The following is a description of a gene set: A type of adult onset with onset of symptoms after the age of 60 years. species: Homo sapiens Human Gene Set: HP_LATE_ONSET Late onset, and this is the list of marker genes: UMOD, LMNA, CLN6, LIPC, NOL3, CAPN3, CYLD (CYLD lysine 63 deubiquitinase), ATXN3, HMCN1, MME, APP, SEC61A1, MYPN, TPM1 (tropomyosin 1), DSC2, SDHD, PDGFRB, CHCHD10, IRS1, MARS1, LAMA4, WFS1, ADH1C, BEAN1, MYH6, AKT2 (NCBI Gene Id 208), UQCRC1, OXGR1, TUBA4A, KCNH5, ABCC8, GPD2, CFHR1, LOX, THSD1, NPTX1, ACTC1, ERBB4, PAX4, MAPT, TGFBI, DGUOK, SFTPA1, TOP3A, HTRA1, NRIP1, ANXA11, TCF7L2, MT-TT, ATXN8OS (NCBI Gene Id 6315), MAFA, GANAB, SEC23B, MTNR1B, CLEC3B, FMR1, MYBPC3, CFHR3 (NCBI Gene Id 10878), OPTN, ELOVL4, TENM4, JAK2, PPARG, BMP6, HNF1A, SMAD2, PTPN1, LRRK2, EIF4G1, HNF1B (HNF1 homeobox B), RPS14, PDX1, VCL (vinculin), APOE, HCN4, TMEM43, FBLN5, BLVRA, ATXN2, KLKB1, GBA1, SNCAIP (NCBI Gene Id 9627), ATN1, HMGA1, EPCAM, GYG1, MAPK8IP1, ITPR1, RETN, TBP, DSG2, HAVCR2, BBS2, HSPB1, NEK8, ENPP1, KCND3, SMARCA4 (SWI/SNF related, matrix associated, actin dependent regulator of chromatin, subfamily a, member 4), SLC30A8, LMX1B, ANLN (anillin, actin binding protein), CHCHD2, TIA1, IRS2, CFH, KCNE2, TARDBP, FLNC, TNNC1, IMPG2, PPP1R3A, TRPM7, NEK1, NEUROD1, UBQLN2, PABPN1, NEXN, BAG3, PDYN, TSPOAP1, SNCA, IL6, THSD4, TTBK2, KRT18 (keratin 18), PSEN2, C1QBP, ABCA7, HNF4A, NAGLU, LDB3, BAP1, SLC2A2, CAV1, GCK, NR4A2, CCNF, IGF2BP2